The following is a description of a gene set: studied in species Mus musculus The chemical reactions and pathways resulting in the formation of coenzyme A, 3'-phosphoadenosine-(5')diphospho(4')pantatheine, an acyl carrier in many acylation and acyl-transfer reactions in which the intermediate is a thiol ester. Mouse Gene Set: GOBP_COENZYME_A_BIOSYNTHETIC_PROCESS, and this is the list of marker genes: Pank2, Slc25a16, Coasy, Dcakd, Slc25a42, Pank3, Pank4, Ppcdc, Pank1, Ppcs, Acat1, Acot7